Given this list of marker genes HTR3B, HTR3C, CHRNA10, HTR3E, HTR3D, CHRNA9, HTR3A, here is a description of the gene set: Human Gene Set: GOMF_SEROTONIN_GATED_MONOATOMIC_CATION_CHANNEL_ACTIVITY studied in species Homo sapiens Enables the transmembrane transfer of a cation by a channel that opens when serotonin has been bound by the channel complex or one of its constituent parts.